Given this list of marker genes Trim62, Dhx9, Pfn1, Rsf1, Trim31, Ifitm3, Ifitm7, Trim8, Trim32, Sp100, Trim14, Trim27, Larp7-ps, Tarbp2, Mid2, Zfp36, Trim13, Ubp1, Notch1, Hexim1, Mdfic, Trim11, Trim21, Map3k1, Larp7, here is a description of the gene set: Mouse Gene Set: GOBP_REGULATION_OF_VIRAL_TRANSCRIPTION Any process that modulates the frequency, rate or extent of the transcription of the viral genome. species: Mus musculus